Given this list of marker genes Ormdl3, Abcg2, Kdsr, Sptlc3, Ormdl2, Cyb5b, Cers5, Fa2h, Degs2, Sptssb, Cers1, Spns2, Sptlc2, Cers4, here is a description of the gene set: electronically inferred by orthology from the curated human pathway This event has been computationally inferred from an event that has been demonstrated in another species.<p>The inference is based on the homology mapping from PANTHER. Briefly, reactions for which all involved PhysicalEntities (in input, output and catalyst) have a mapped orthologue/paralogue (for complexes at least 75% of components must have a mapping) are inferred to the other species. part of: Sphingolipid metabolism Reactome Pathway: Sphingolipid de novo biosynthesis studied in species Mus musculus